Given this list of marker genes Chtf8, Rfc3, Chtf18, Rfc2, Dscc1, Rfc5, Pcna, Polg2, Rfc4, here is a description of the gene set: Mouse Gene Set: GOBP_POSITIVE_REGULATION_OF_DNA_DIRECTED_DNA_POLYMERASE_ACTIVITY studied in species Mus musculus Any process that activates or increases the frequency, rate or extent of DNA-directed DNA polymerase activity.